Given this list of marker genes MUC12, MUC13, GALNT3, MUC16, MUC17, MUC15, MUC7, MUC5B, MUC1, MUC4, MUC20, MUC3A (mucin 3A, cell surface associated), MUC21, MUC6, MUC5AC, MUCL1 (NCBI Gene Id 118430), here is a description of the gene set: studied in species Homo sapiens Human Gene Set: REACTOME_DEFECTIVE_GALNT3_CAUSES_HFTC Defective GALNT3 causes HFTC